The following is a description of a gene set: An inflammatory response resulting in cell death or dysfunction mediated by activation of the classical complement pathway or induction of effector cell phagocytosis, cytolysis mechanisms via complement or Fc receptors following the binding of antibodies to cell surface antigens on a target cell, or mediated by the direct binding of antibody to cellular receptors. studied in species Homo sapiens Human Gene Set: GOBP_TYPE_II_HYPERSENSITIVITY, and this is the list of marker genes: FCGR1A, FCGR2C, IGHE, FCER1G, FCGR2B, C3, FCGR3A, HLA-E, FCGR2A, FCGR1BP, FCGR3B, IGHG1